Given this list of marker genes KRAS, GJA5, MAPK1, ASXL2, BMPR1A, TMEM260, POLR1A, SUCLG1, ARSL, CUX1, YY1, RPL3L, IFT56, COG7, ATP6V1A, NPHP3, RAB23, TRIO, LETM1, BRCA1, VPS35L, B3GLCT, UPF3B, RAF1, DLG5, CDK13, HSPA9, CCNO, POR, H4C9, RSPH1 (NCBI Gene Id 89765), CFAP53, RPL35A, NKAP, PIGF, CREBBP, SGO1, FLII, RPS7, CHD4, SLC29A3, SPEF2, LAMA5, FANCE, PIEZO1, PRDM13, MAP2K1 (mitogen-activated protein kinase kinase 1), RARB, ROBO4, KAT6B, RPL15, VEZF1, GDF1, ZDHHC9, ZMYND10, KAT6A, IPO8, ELN, DNAH5, BRAF, DEF6, KDM5A, SMARCB1, EPG5, THOC6, FANCB, CTCF, METTL5, STRA6, MED25, TGFB3, RRAGC, EXT2, CACNA1D, BMP2, SOS2, MYRF, TGDS, STAMBP (NCBI Gene Id 10617), SMAD3, PAX3, PSMD12, IDH1, CUL3, AMER1, NEK10, NKX2-1, KMT2A, ZIC3, DPH5, EPHB4, CDC42BPB, NME8, NDUFB11, ZBTB7A, RBM8A (RNA binding motif protein 8A), BCOR, CBL, RPL35, BRD4, IFT172, H4C3, PLD1, NUP155, TRAF7, RNU4ATAC, ZNF341, GPC4, NELFA, KATNB1 (katanin regulatory subunit B1), LMNB1, RPL26, HRAS, RSPH4A, BUB1, EP300, ABL1, CEP295, OTUD6B, STRADA (NCBI Gene Id 92335), UBR7, CHMP1A, G6PC3, DNAH1, SH3PXD2B, KMT2D (NCBI Gene Id 8085), ZMYM2, WASHC5, EIF2AK3 (eukaryotic translation initiation factor 2 alpha kinase 3), RPS28, DNAH11, MAP3K7, RAC1, AFG2A (AFG2 AAA ATPase homolog A), FRA10AC1, WDR35, ESCO2, VAC14, SRCAP, LIMK1, SMAD2, IFT27, DPF2, FANCC, TLL1, HYDIN, TBX5, SMN1, MMP21, BAZ1B, RPL11, NSD2, SLX4, IGF1R, FTCD, PEX2, VPS33B, SOX11, INSR, CLCN3, RIT1, POLR3A, ABCC6, CEP57, NKX2-5, TWIST1, CFAP298, RBM10, AGO2, RSPRY1, ATIC, CDC45, HEATR3, DNAJB13, SKIC2, OCLN, DCPS, DNAAF5, MYOCD, ESAM, SLF2, CCDC22, TNNI3, TBX1, RERE, HCCS, PLXND1, CSGALNACT1, DNAAF2, FLNB, NRAS, MLXIPL, GJA8, RRAS2, HACD1, FANCG, TKT (NCBI Gene Id 7086), RPS27, NAA10, DNAJC30, PPP2CA, COMT, SLC35A2, CPE, GATA4, KDM5B, SALL4, USP9X, RFWD3, AGR2, DBR1, STAG2, EVC, PTEN, AHI1, BUB3, GAS2L2, RFC2, GNPTAB, SKIC3, GATA1, SETBP1 (SET binding protein 1), IRX5, ARID2, EVC2, MED11, TGFBR2 (NCBI Gene Id 7048), PPFIBP1, TMCO1, FGFR3, BUB1B, PPP1R21, TRAIP, ODAD3, AMMECR1, COL11A1, CDK10, RREB1 (ras responsive element binding protein 1), KIF11, PIGA, SPECC1L, FANCF, KANSL1, TMEM147, ODAD1, SIAH1, MTX2, CLIP2, BANF1, FLNA, NDE1, POGZ, DLK1, ARID1A, ADNP (NCBI Gene Id 256440), DACT1, DPH1, RPS10, SNRPN, MBTPS2, ACVR2B, UFD1, DNAJC19, SLC25A24, SLC25A36, FANCA, PIGT, SMC3, DNAAF1, MMP14, FANCD2, DNAAF4, MCIDAS, GLI3, BUD23, GJA1, RPGR, ECE1 (endothelin converting enzyme 1), CDK8, EFTUD2, ATN1, JAG1, KIAA0586, CFAP221, ADK, RASA2, HNRNPK, PIGN, UBE2T, TASP1, GATA6, SYT1, PGAP2, LRRC56, SON, RSPH9, THSD1, NCF1, TTC12, BBS2 (Bardet-Biedl syndrome 2), MEGF8, RIPK4, CCDC40, STK36, XRCC2, PRIM1, MEIS2, PTF1A, SHOC2, ANK1, TSFM, COG6, EOGT, DHCR7, PRRX1, SMG8, SLC19A2, WDR37, DRC1, RPS17 (ribosomal protein S17), SNRPB, WT1, MRPL3, DYNC2LI1, CRKL, DNAAF6, FGFRL1 (fibroblast growth factor receptor like 1), ARVCF, CTBP1, B3GAT3, DNAAF11, MYL2, RPL10, MAPKAPK5, GTF2IRD2, NEK9, PCGF2, CLXN, GYS1, SDHD, ZNF668, ROBO1, SEC24C, ROR2, C2CD3, ASCC1, RAD21, ERCC4, TBX20, FOXJ1, TNNT2, KIF15, MEG3, CEP290, LTBP4, PALB2, LARP7, FGFR1, UBE3B, PKDCC, AGGF1, GNB5, KCNH1, NCAPG2, UFC1, ZFX, USP18, FOXP2, TAF6, CHRM3, FLNC, FHOD3, SMC1A, XYLT2, FUT8, RSPH3, GPC3, PIGG, GET3, ACTA2, SOS1, PIK3R2, FBXW11 (F-box and WD repeat domain containing 11), ZMPSTE24, ATP2B1, MAP2K2, RTL1, ITPR1, METTL27, RAD51C, ERI1, ABCD4, NEK1, FANCI, ARHGAP31, ZEB2, CPLX1, ANAPC7, FBXL4, STAT1, NONO, RAD51, VPS33A, FGFR2, H3-3B, SPAG1, BICRA, EIF4H, PGAP1, TALDO1 (transaldolase 1), DPYSL5, AFF4, PQBP1, GPC6, LZTR1, COL1A1, EHMT1, NODAL, ALG12, FKBP6, DAW1, CHD7, DSE, ZNF699, FHL1, KIF20A, NXN, NKX2-6, TBL2, CTU2, FANCM, CCNQ, ATP6V1E1, MKKS, RPS15A, RPS29, GLI1, NOTCH1, B3GALT6, ASXL1, DNAL1, SPRED2, ODAD4, GPX4, ADAT3, FRMD5, SALL1, NME5, KDM1A, RPL9, ALG9, MAX, TXNL4A, LMOD2, NIPA2, PRKACB, SCN1B, PPP2R5D, SMAD4 (NCBI Gene Id 4089), RPL5, UBE2A, ARID1B, CFAP45, SZT2, MCM10, TBX2 (T-box transcription factor 2), TBX22, EIF4A2, DNA2, PEX19, HIRA, KDM6A, FBXO11, SHMT2, OFD1, CCDC39, UQCRC2, DNAH9, DDX6, CHST3, PPP1CB, FOCAD, SOX4, TMEM270, GP1BB, TSR2, MID1, FANCL (FA complementation group L), TRIP4, CHD3, PPP1R13L (NCBI Gene Id 23453), NIPBL, GTF2IRD1, MMP2, MPDZ, ACADVL, PRR12, DVL3, MOGS (mannosyl-oligosaccharide glucosidase), RPS24, PTPN11, DNAI2, POLA1, AUTS2, MYBPC3, WBP4 (WW domain binding protein 4), TBC1D24, SIK3, DOHH, AHDC1, EBF3, AXIN1, BRIP1, SLC38A3, DPH2, STK4, JMJD1C, GTF2I, NSD1, MED12, TMEM94, ATP9A, RAI1, NF1, UBR1, MASP1, MAGEL2, RPL8, BRCA2, MYH6, MYH7, APC2, ODAD2, H3-3A, SMARCA4, SMARCE1, PACS2, CFAP300, CORIN, NDUFB7 (NCBI Gene Id 4713), LMBRD1, SMARCD1, PHGDH, SCUBE3, PIGO, UMPS, RRAS, BCR, PACS1, TRIP13, MYL3, CFC1, TRRAP, CFAP74, RPL27, FGF13 (NCBI Gene Id 730528), NIPA1, RPL31, LONP1, SCN5A, CCBE1, FKTN, FIG4, ACTC1, FILIP1, RPS26 (ribosomal protein S26), HDAC8, RPS19, NPPA, FOXF1, TBX4, KAT8, RPL18, CITED2, MAD2L2, CHST14, PKD1L1, MRAS, COL1A2, ADA2, FBN2, CACNA1C, RELN, HNRNPH2, MYPN, FLCN, LMNA (NCBI Gene Id 7816), TUBG1, SMAD6, NFE2L2, GATA5, SNX14, TGFBR1, DNMT3A, SH2B1, DNAI1, RPS20, FOXC1, SETD1A, HAAO, NOTCH2, DNAAF3, SMARCC2, PCNT, STX1A, WLS, MED13L, VPS37D, NR2F2, MED23, COX7B, NFIX, CARS1, PIK3CA, PRKACA, CIROP, here is a description of the gene set: Any structural abnormality of a cardiac atrium. Abnormal cardiac atrium morphology Human Gene Set: HP_ABNORMAL_CARDIAC_ATRIUM_MORPHOLOGY studied in species Homo sapiens